The following is a description of a gene set: species: Homo sapiens Human Gene Set: GOCC_RNA_POLYMERASE_II_CORE_COMPLEX RNA polymerase II, one of three nuclear DNA-directed RNA polymerases found in all eukaryotes, is a multisubunit complex; typically it produces mRNAs, snoRNAs, and some of the snRNAs. Two large subunits comprise the most conserved portion including the catalytic site and share similarity with other eukaryotic and bacterial multisubunit RNA polymerases. The largest subunit of RNA polymerase II contains an essential carboxyl-terminal domain (CTD) composed of a variable number of heptapeptide repeats (YSPTSPS). The remainder of the complex is composed of smaller subunits (generally ten or more), some of which are also found in RNA polymerases I and III. Although the core is competent to mediate ribonucleic acid synthesis, it requires additional factors to select the appropriate template., and this is the list of marker genes: POLR2M, POLR2L, POLR2G, POLR2J2, POLR2I, TUFT1, POLR2C, POLR2J, POLR2E, POLR2H, POLR2D, POLR2K, POLR2J3, POLR2B, POLR2A, MYZAP, POLR2F